The following is a description of a gene set: A process that is carried out at the cellular level which results in the assembly, arrangement of constituent parts, or disassembly of a stereocilium. A stereocilium is an actin-based protrusion from the apical surface of inner ear receptor cells. Human Gene Set: GOBP_INNER_EAR_RECEPTOR_CELL_STEREOCILIUM_ORGANIZATION species: Homo sapiens, and this is the list of marker genes: MKS1, TRIOBP, GRXCR1, IFT27, REST, MINAR2, PJVK, NHERF1, ELMOD3 (ELMO domain containing 3), ANKRD24, OTOGL, GRXCR2, CLRN1, SOD1, HES5, MYO7A, CECR2, TTC8, STRC, PLS1, WHRN, IFT88, HES1, ADGRV1, TECTA, CTHRC1, PDZD7, CDH23, TRIP11, CLRN2, LHFPL5 (NCBI Gene Id 613035), SDC4, IFT20, TSKU, VANGL2, SCRIB, TPRN, USH1G, USH1C, SEC24B